Given this list of marker genes NCF2, IRF8, RBM38, MS4A1, HK3, S100P, GSTA2, CXCL10, SEPTIN6, PLEK, NCF1C, SNAP25, CFP, FLT3, MELK, MLLT11, HCK, NCF4, LGALS4, LILRA2, MSMB (microseminoprotein beta), ITGAM (NCBI Gene Id 3684), RHOH, LIPA, LYN, PFKFB4, RPA1, RRM2, CCL19 (NCBI Gene Id 6363), CEACAM5, HMGCS2, SECTM1, CITED2, DEFB1, PRSS1, FCN1, MNDA, DDX17, C5AR1, PRSS3, ITGB7, KRT13, SEMA4D, CDK1, CEL, SPINK1, BCL2A1, IRAG2, POU2AF1, PTGS2, FXYD2 (NCBI Gene Id 486), FABP1, CD247 (CD247 molecule), CELA2B, PCP4, PRTN3, DBN1, RAC2, FYB1, CPA1, FOXG1, MPO, NKG7, HSPA6, NPAS1, GPX2, PLA2G7, GZMK, CXCL9, TLR1, NINJ1, CSF3R, ETS2, TSPAN8, DNTT, UMOD, CLEC2B, CD27, LCP2 (lymphocyte cytosolic protein 2), PLIN2, NPY, SPI1, here is a description of the gene set: species: Homo sapiens Human Gene Set: MODULE_165 Genes in the cancer module 165.